The following is a description of a gene set: Underdevelopment of a fingernail. Human Gene Set: HP_HYPOPLASTIC_FINGERNAIL Hypoplastic fingernail species: Homo sapiens, and this is the list of marker genes: ARID1B, FBXO28, SHOX, IGF2, PTDSS1, WASHC5, TFAP2A, ZNF462, HYMAI (hydatidiform mole associated and imprinted), SMARCB1 (NCBI Gene Id 6598), DPYSL5, COL11A1, KCNH1, SMARCA4, SOX11, PIGO, CDKN1C, TWIST2, EOGT, RBPJ (NCBI Gene Id 51580), ARID2, DLL4, BMPER, SMARCC2, TBC1D24, ATP6V1B2, PGAP2, COL11A2, SOX4, NOTCH1, PIGN, ROR2, IKBKG, VPS35L, PLAGL1, FGFR2, MSX1, CENPT, PLAG1, PLEC, CCDC22, HMGA2, KCNN3, PIGF, RPS6KA3, SMARCD1, MBTPS2, DOCK6, ARHGAP31, ERI1, ARID1A, SMARCE1, DPF2